The following is a description of a gene set: The process in which a relatively unspecialized cell acquires specialized features of a myotube cell. Myotube differentiation starts with myoblast fusion and the appearance of specific cell markers (this is the cell development step). Then individual myotubes can fuse to form bigger myotubes and start to contract. Myotubes are multinucleated cells that are formed when proliferating myoblasts exit the cell cycle, differentiate and fuse. Mouse Gene Set: GOBP_MYOTUBE_DIFFERENTIATION studied in species Mus musculus, and this is the list of marker genes: Gsk3b, Mymx, Cav2, Cntnap2, Fktn, Rcan1, Neo1, Ins2, Myh9, Shh, Met, Xk, Tmem182, Hdac9, Atp11a, Selenon, Nln, Cflar, Daxx, Nphs1, Six4, Stac3 (SH3 and cysteine rich domain 3), Bin3, Dock1, Pmp22, Kel, Adgrb1, Six1, Smyd1 (NCBI Gene Id 97290), Ehd1, Dmpk, Tbx1, Capn2, Myocd, Col6a1, Ppp3cb, Il4ra, Bdnf, Rbm24, Adamts5, Itgb1, Mymk, Gdf15, Dyrk1b, Bcl9, Adamts15, Smyd3, Flot1, Homer1, Myod1, Ccn3, Sort1, Maml1, Cdon, Mir351, Piezo1, Csf1r, Klhl40, B4galnt2, Neu2, Ehd2, Bhlhe41, Dock2, Igf1, Plec, Myorg, Cntnap1, Rbm38, Hacd1, P2rx2 (NCBI Gene Id 231602), Rpl3l, Barx2, Pld3 (phospholipase D family member 3), Lncpint, Notch1, Ppp3ca, Mtor, Mapk14, Hdac5, Klf5 (Kruppel-like transcription factor 5), Cyp26b1, Actn3, Cxcl9, Myf6, Cxcl10, Plekho1, Scgb3a1, Wnt10b, Large1, Dner, Dmd, Myf5, Flt3l, Fkrp, Shox2, Avpr1a, Csrp3, Cxcl12, Tmem119, Adgrb3, Plpp7, Gpx1, Norad, Ripor2, Cav3, Mmp14, Sik1, Casp1, Il4, Ski, Ankrd2, Spg11, Nkx2-5, Cacna1s, Ccl8, Hdac4 (histone deacetylase 4), Bhlha15, Nfatc3, Tanc1, Cd9, Lmod3, Dcaf8, Myc, Smo, Syna, Synb, Hottip, Cd81, Myhas, Cd53, Trim63, Ntn3, Acta1, Stim1, Ppif, Il36g, Dock5, Tnfsf14, Wnt1, Bcl2, Trim72, Ryr1, Xbp1, Nfatc2, Ptgfrn, Fbxo22, Mamstr, Myog, Igfn1 (immunoglobulin-like and fibronectin type III domain containing 1)